The following is a description of a gene set: Mouse Gene Set: MIR_343 Genes predicted to be targets of miRBase v22 microRNA mmu_miR_343 in miRDB v6.0 with MirTarget v4 prediction scores > 80 (high confidence targets). from publication Chen Y, Wang X (PMID 31504780) studied in species Mus musculus, and this is the list of marker genes: Atg14, Kpna1, Sec22b, Edn1, Csmd1, Sin3a, Speg, Mybl2 (myeloblastosis oncogene-like 2), Rrm2b, Btn1a1 (butyrophilin, subfamily 1, member A1), Pnma5, Grhl2, Glis2, Creb5, Robo2, Gbp5, Barx2, Hmox1, Ghr, Zfp395, Apln, Dusp6, Tmem121b, Nufip1, Ctso, Plcb1, Nudt13, Irf2, Cckar, Abhd2, Fam168b, Frmd4a, Ifit2, Dll4, Synj2bp, Efemp2, Rbm24, Ddx3x, Map2k6, D1Pas1 (NCBI Gene Id 98517), Znrf3, Trip13, Klf2, Fgf7, Amot, Vbp1, Fuca2, Tbck, Shprh (SNF2 histone linker PHD RING helicase), Aph1a, Rnft2, Zbtb41, Pold3, Pm20d1, Slc22a15, Sgcz, Asic1, Vps13d, Hoxa10, Slc38a1, Mtpn, Nfasc, Fam117b, Kcnk10, Ptger3, Cd247, Top1, Xpo7, Frmd5, Enah, Trpc5, Metap1, Ehf, D430041D05Rik, Amigo1, Comt, Sox12, Kcnmb2, Taf5, Copg2, Slc35c1 (solute carrier family 35, member C1), Ino80d, Aplf